Given this list of marker genes CDC37, ERBIN, HSP90AA1, ERBB2, here is a description of the gene set: species: Homo sapiens Reactome Pathway: Drug resistance in ERBB2 KD mutants part of: Signaling by ERBB2 in Cancer ERBB2 kinase domain (KD) mutants vary in their resistance to various tyrosine kinase inhibitors and therapeutic antibody trastuzumab (herceptin). The following ERBB2 KD mutants are resistant to the therapeutic antibody trastuzumab (herceptin):<br><br>ERBB2 L755P;<br>ERBB2 L755S;<br>ERBB2 I767M;<br>ERBB2 D769Y;<br>ERBB2 V777L;<br>ERBB2 G778_P780dup;<br>ERBB2 T798M;<br>ERBB2 V842I;<br>ERBB2 T862A;<br>ERBB2 L869R;<br><br>For ERBB2 R896C, both resistance and sensitivity to trastuzumab have been reported.<br>